Given this list of marker genes LPP, STX3, JUNB, CYP21A2, RIMS4, RNASEH2C, SLC30A8, THG1L, SZRD1, DAAM2, USP22, ZNF541, TAOK3, ANGPT1, TACR2, TUBG2, SIRPA, PI4K2A, C9orf152, SRCIN1, AFTPH, ENTPD1, LARP1, KCNE5, SNX18, ZNF703, CHST14, CLASP1, ZNF423, DRD2, PPP1R12B, FMO5, SLC13A5, NOVA1, LZTS1, TUBA4A, RAD50, GFRA1, CECR2 (CECR2 histone acetyl-lysine reader), DOCK5, SGSM3, NFASC, GFOD2, ANKRD45, SDK1, FOXP4, STIM1, FKBP4, LHX6, WBP2 (NCBI Gene Id 96240), TBC1D10B, IKZF4, SOCS7, NLK, COLGALT2 (NCBI Gene Id 23127), GLRA2, GORASP1, ZNF664, TPBGL, CREBRF (CREB3 regulatory factor), CD164, GOSR2, MSMO1, PIANP, CACNA1C, PTPRD, GTPBP3, RBMS3, MNT, SOX11, APBB1IP, NTRK3, CPD, TAOK2, DEDD, PTK2, MAFG, EYA3, RGS8, GOLGA1, SSR1 (signal sequence receptor subunit 1), SPRY4, SYT7, NOVA2, ZNF324B, LRATD2, PLXNA2, SH3PXD2A, ANGEL1, ATP2B4, CMTR1 (NCBI Gene Id 23070), NDUFA11, SNAI2, SLC25A44, GAS7, CCDC97 (coiled-coil domain containing 97), MBLAC1, CSF1, RARG, MAP3K3, SS18, MLKL, AMMECR1, SCMH1, FBRS, TTR, TOR1AIP2, MTCL2, HIC1, VPS35, BTRC, ZNF365, DPP3, FAM131B, FMNL3, CYP26B1 (NCBI Gene Id 56603), SYNPO, TXN2, SLC35E2A, MIF4GD, DNMT3A, DACT3, DLK1, MOB3B, COL16A1, EOMES, MED26, CNDP1, VEGFA, DDX27, POLDIP3, GRAMD1B, ZFYVE27, PRKACA (protein kinase cAMP-activated catalytic subunit alpha), SNX2, CARD18, XDH, RBFOX1, UBE2R2, NKIRAS2, NDE1, ADCYAP1R1, HTN1, ZFP3, STX16, HOXB9, VAMP3, ARGFX, KIF21B, MXI1, RABL6, SCUBE1, CNTLN, GABARAP, PACSIN1 (NCBI Gene Id 57564), PFDN1, MLEC, SLITRK1, ZBTB33, LAMP3, SHISA7, EFNB1, CNOT7, IQSEC2, EFNA3, AKAP6, TFCP2L1, ZBTB4, CRMP1, PDPR, TRPM6, SHISA6, DCX, ITGA7 (NCBI Gene Id 81988), AGAP2, POU3F4, CD300LD-AS1, PAX1, PDE4A, TTLL6, SLC41A1, GLYCTK, SMARCC1, SSH2, SLC25A11, PLCD4, SET, FKBP5, FGF12 (NCBI Gene Id 2257), C1QTNF6, ZNF862, PSME3, PLEKHA2, WNT1, SCAMP5, BAZ2A, SCRT2, NDUFA10, NFAT5, CTXN1, DUSP16, IL2RG (NCBI Gene Id 3561), APTX, STAT2, PML, BCAP31, KCNH1, JPH2, PTPA, SUSD6, EPDR1, APBA1, ZNF436, DNMT3B, ZBTB7B, GSK3B, MECR, RPH3A, HCN4, FGD4, SLC2A4, DNAAF10, SIX2, PPP2R2A, AP3B1, NUB1, SHH (NCBI Gene Id 6469), SLC35E2B, BPIFB4, CEP85, RUNX3, GPR173, CD38, H2AX, SV2A (NCBI Gene Id 9900), ERGIC1, KCNH7, KAT7, TBC1D30, ELFN2, MECP2, ZDHHC23, PPP3R1, DENND6A, PRSS23, SPRED2, ZHX3, DHDDS, CKAP4, CCN1, here is a description of the gene set: from publication Chen Y, Wang X (PMID 31504780) studied in species Homo sapiens Human Gene Set: MIR3202 Genes predicted to be targets of miRBase v22 microRNA hsa-miR-3202 in miRDB v6.0 with MirTarget v4 prediction scores > 80 (high confidence targets).